Given this list of marker genes Uap1l1, Rnf126, Anp32b (acidic nuclear phosphoprotein 32 family member B), Hnrnpd, Sparc, Nsd3, Gstm1, Niban2, Scand1, Cyba, Klf13, Drap1, Olfml3, Pfn1, Map2k2, Ywhae, Tle5, Snrpc, Hivep2, Gata3, Rps3, Gpr132, Gsn (gelsolin), Gnb1, Anapc11, Ssbp4, Rab5c, Ptms, Lamtor4, Dpt, Jund, Bri3, Reep5, Arl8a, Hcls1, Sdhc, Cyth4, Csf2ra, Tomm6, Cdv3, Cuedc2, Rpl13a, Timp3, Cotl1, Otub1, Dpysl2, Apoe, Cfl1, Lad1, Ube2m, Emc10, Ybx1, Twf2, Dcn, Psap, Arrb2 (NCBI Gene Id 216869), Crlf2, Cavin1, Emp3, Kdm6b, Furin, Lum, Spi1, Tmsb10, Eif4a1, Gpx3, Ccdc80, Ifitm2, Arhgdia, Pkm, Tmem160, Sf3b4, Blvra, Lgals3, Nr4a1, Ptma, Pmp22, here is a description of the gene set: Mouse Gene Set: TABULA_MURIS_SENIS_MESENTERIC_ADIPOSE_TISSUE_MACROPHAGE_AGEING from publication Tabula Muris Consortium (PMID 32669714) studied in species Mus musculus